The following is a description of a gene set: studied in species Mus musculus Mouse Gene Set: GOBP_REGULATION_OF_SMOOTH_MUSCLE_CONTRACTION Any process that modulates the frequency, rate or extent of smooth muscle contraction., and this is the list of marker genes: Kit, Ptgs2, Ptgs1, Edn1, Edn3, Gucy1a1, Zdhhc21, Oxt, Tbxa2r, Abat, Tacr2 (NCBI Gene Id 21337), Flt1, Npy2r (neuropeptide Y receptor Y2), Adrb2, Ptafr, Chrnb4, Pawr, Rgs2, Lck, F2r, Atp1a2, Ghrl, Cald1, Chrm2, Setd3, Adra1a, Irag1, Edn2, Oxtr, Ptger3, Sphk1, Shc1, P2rx1, Kcnma1, Tacr3, Adra2b, Calcrl, Dock4, Srf, Atp2b1, Stub1, Spx, Prok2, Ghsr, Cttn, Tacr1, Ptger4, Adra2a, Ada, Myocd, Adrb1, Cav1, Rhoa, Prkg1 (NCBI Gene Id 381235), Itga2, Npnt, Adora2b, Map2k1, Gper1, Adra2c, Tnni3, Nmu, Chrna3, Sod1, Chrm3, Calca, Arhgap42 (Rho GTPase activating protein 42), Ormdl3, Dock5, Htr7